Given this list of marker genes Rps25, Plec, Psmb1, Mcl1, Litaf, Medag, Txnip, AW112010, Npc2, Eif3k, Comt, Mycbp2, Foxp1, Eif3m, Selenbp1 (NCBI Gene Id 229585), Rpl41, Rps6, Iah1, Vamp5, H2aj, Rpl35a, Mgst1, Rps27a, Rps15a, Rps19, Ms4a4d, Rps10, Rps18, Aebp1, Cygb, Npm1, Zfas1, Rpl10a, Entpd2, Ralbp1, Scd1, G530011O06Rikx, Lgals1, Rpl22l1, Rpl5, Tgfbr1, Map1lc3b, Smoc2, Inmt, Vim, Fos, Tnxb, Sdf4, Thbd (thrombomodulin), Hsd11b1, Hspb1, Ces1d, Rps17, Tspo, Cd74, Cirbp, Tpt1, Mfap5, Gm15421, Pcsk6, Mir703, Col8a1, Fth1, Gpx1, Rps3, Sfrp1, Stat3, Tmem176a, Dpep1, Serping1, Nr4a1, Crip1, Rpl23, Rpl27a, Ctsb, Fbln2 (NCBI Gene Id 74839), Selenop, Maff, Lrp1, Ngf, Rpl23a, Ahsg, Eef2, Cd55, Lsp1, Capg, Tmem140, S100a6, Timp1, Lbh, Eef1a2, Slfn5, Eef1d, Rpl21, Rpl13, Anxa1, Arpc1b, Rpl31-ps12, Cxcl1, Pi16, Mmp14, Ifi205, Ctdsp2, Rpl19, Rbm3, H2-Q4, C3 (NCBI Gene Id 12266), Rack1, Rpl35, Rpl3, B2m, Rps14, Cyb5r3 (NCBI Gene Id 97979), Nbl1, Nsa2, Sox9, Cytl1, Rps2, Gpsm3, Add3, Rpsa, Nop53, Rpl38, Sod1, Rps13, Mustn1, Plac9, Rsrp1, Fosl2, Ifitm2, Rpl10, Cd302, Rpl13a, Pltp (NCBI Gene Id 18830), Vat1, Carhsp1, Cd47, Clmp, Snai1, Eef1b2, Scn7a, Efemp1, Slc43a3, Sqstm1, Rpl11, Rplp2, Tmem176b, Rpl22, Mndal, Prr13, Ifitm3, Mrpl33, Rpl18a, Klf2, Cox7a2l, Ly6a, Rps8, Hk2, Svep1, Rpl24, Eef1a1, Sod3, Enc1 (ectodermal-neural cortex 1), Uap1, Rpl4, Gda, Rpl37, Aox3, Igfbp6, Mt1, Fxyd6, Naca, Ifi207, Gstm2, Mmp3, 2410006H16Rik, Bst2, Gas5, Rpl39, Rspo1, Vwa1, Anxa3, Cdkn2c (cyclin dependent kinase inhibitor 2C), Zfp36l2, Wdr89, Ifi27l2a, Bgn, Ftl1, Rtraf, Il33, Apbb1ip, 1810037I17Rik, Klf4, Enpp2, Rab3d, Nppa, Pnrc1, Rplp1, Rps11, Ly6e, Rps15, H2-K1, Myoc, Ccn1, Rpl15, Icam1, App, Rpl36a, Ier3, Clec3b, Penk, Rps7, Crip2 (cysteine rich protein 2), Rps12, Man2a1, Tmem254, Socs3, Rpl12, Rps29, Rnase4, Rps27, Id2, Eif3h, Sparcl1, Gsta3, Rps24, Rpl29, H2-D1, Kmt2e, Rps16, Use1, Cpne8, Rps28, Rps9 (ribosomal protein S9), Rpl27, Pgls, Snhg8, Fabp4, Pabpc1, Rpl32, Gpx3, Pcolce2, Neat1, Plat, Mgll, Xdh, Fxyd5, Pde1a, Rps3a1, Gfpt2, Id3, Gstm1, Rpl6, Rpl31, Rps15a-ps6, H2-T23, Eif3e, Bhlhe40, H2bc4, Ccn2, Rpl18, Rpl7, Rhoj, S100a13, Ifi203, Fmo2, Rps4x, Pfdn5, Cxcl16, Zfp36l1, Atp5mc2, Eif3f, Rps20, Rpl37a, Pam, Vcam1, Cyb5a, Txn1, Rpl14, Rps5, Rplp0, Gpi1, Serpine2, Cp, Rpl17, Fau, Rbp1, Clta, Pdpn, Btf3, Mt2, Grina, Trf, Scara5, Psmb8, Rpl7a (NCBI Gene Id 30787), Emp1, Gpm6b, Rps21, Rpl36, Faim2, Htra4, C4b, Ssbp4, Uba52, Cltb, C1ra, Pdlim2, Smim41, Junb, C1s1, Rps23, Ly6c1, here is a description of the gene set: from publication Tabula Muris Consortium (PMID 32669714) Mouse Gene Set: TABULA_MURIS_SENIS_HEART_AND_AORTA_FIBROBLAST_OF_CARDIAC_TISSUE_AGEING species: Mus musculus